Given this list of marker genes Tmem237, Gm8357, Orc2, Gm7063, Gm19124, Gm6644, Aox3, Gm8296, Satb2, Gm19637, Gm6799, Ormdl1, Mstn, Gm8326, Gm8354 (predicted gene 8354), 1700072G22Rik, Gm23240, 9330175M20Rik, Sgo2a, Pgap1, Hycc2 (NCBI Gene Id 52084), Col5a2, Wdr75, Gm31812, Gm5268, Gm8304, Nab1, Gm29040, Ccdc168, Gm8531, Gm8420, Gm23460, Ankrd44, Hibch, Gm26352, Gm5253, Gm28650, Gm18849, Gm6801, Gm8307, Gm29155, Gm22371, Dnah7a, Ppil3, Gm8367 (predicted gene 8367), Gm28893, Gm24548, Gm20118, Flacc1, Kctd18, Gm5527, Gm3496, Nck2, Clk1, Myo1b, Rpl23a-ps1, Poglut2, Gm5254 (NCBI Gene Id 383509), 1700003I22Rik (NCBI Gene Id 69356), Gm15759, Cdk15, Gm8581, Pms1, Gm8384, 1700019A02Rik, Gm5147, Spats2l, Gls, Gm16581, Gm3940, Tyw5, Gm19587, Coq10b, Gm16103, Boll (NCBI Gene Id 75388), Gm28777, Gm8241, Gm53065, Sf3b1, Gm29389, C2cd6, Aox4, Gm28900, Aox1, Gm34066, Tmeff2, Tpp2, 4930521E06Rik, Bivm, E330011M16Rik (NCBI Gene Id 100313512), Gm17971, Ndufb3, Ccdc150, Stk-ps2, 9130227L01Rik, Gm5974, Stat1, Gm18802, Gm6822, Cflar, Hecw2, Stk17b, Slc39a10, Bzw1, Rps27a-ps1 (ribosomal protein S27A, pseudogene 1), Gm5700, Asnsd1, Dnah7c, Gm5269, Maip1, Stradb, 4933411E06Rik, Stat4, Tex30, Gm8419 (predicted gene 8419), Col3a1, Ercc5, Gm24349, Hspd1, Mir7681, Cbx3-ps7, Gm5976, Ecrg4, 9130024F11Rik, Gm8391, Gm5975, Gm8292, Gm19206, Mettl21e, Nif3l1, Uxs1, Gm10561, Trak2 (NCBI Gene Id 98647), Gm29018, 4930444A19Rik, A130048G24Rik, 1700019D03Rik, Gtf3c3, Cavin2, Gulp1, C230029F24Rik, Mettl21c, Gm17767, Asdurf, Gm25502, Inpp1, Aox2, Hspe1, Gm5526, Gm8337, Osgepl1, Nemp2, Gm20257, 4930558J18Rik, 1700066M21Rik, Casp8, Gm3605, Gm3489, Mir6350, 1700126A01Rik, Gm28321, Rftn2, Gm24251 (NCBI Gene Id 115487670), Dnah7b, Mfsd6, Plcl1, Gm16107, Gm22360, Gm28802 (predicted gene 28802), Gm19125, Txn-ps1, Gm19480, Mars2, Gm3841, Gm16102, Gm29610, Gm28178, Gm15833, Gm18303, Gm4081, Gm18800, Slc40a1, Gm6757, Hsfy2, Mpp4, Gm4852, Gm17929, Gm18117, Gm23974, Gm15834 (predicted gene 15834), Gm18301, Gm9496, G730003C15Rik, BC055402 (cDNA sequence BC055402), Gm3852, Nabp1, Als2, Mob4, Btf3-ps17, here is a description of the gene set: species: Mus musculus Mouse Gene Set: chr1C1